Given this list of marker genes DAG1, CDON, WNT3, MUSK, CRPPA, KIAA0586, PIEZO2, PPP1R12A, CILK1, L1CAM (NCBI Gene Id 4268), STAG2, MBTPS2, POMGNT2, WDR11, PTDSS1, KIF7, LARGE1, NDUFB11, POU1F1 (POU class 1 homeobox 1), OTX2, EZH2, FGFR2, SOX2, PROP1, CSGALNACT1, LHX4, FOXA2, GPR161, CTBP1, RXYLT1, CSPP1, EHMT1, POMGNT1 (NCBI Gene Id 55624), COL18A1, GLI2, HCCS, ROBO1, PIGA, FKRP, KRAS, POMT2, NSD2, CDC42BPB, TBX4, FANCI, LETM1, DYNC1I2, ZSWIM6, CPLX1, PLCH1, FGFR1, PROKR2, FKTN, SOX3 (SRY-box transcription factor 3), ARNT2, POMK, B4GAT1, HESX1, FGFRL1, DHCR24, NFIX, COX7B, POMT1, CNOT1, COL4A1, B3GALNT2, RSPO2, SSR4, HYLS1, here is a description of the gene set: studied in species Homo sapiens Absent septum pellucidum Absence of the septum pellucidum (meaning translucent wall in Latin - SP), also known as the ventricle of Sylvius. The septum pellucidum is a thin, triangular double membrane separating the frontal horns of the right and left lateral ventricles of the brain. It extends between the anterior portion of the corpus callosum, and the body of the fornix and its width varies from 1.5 to 3.0 mm. Human Gene Set: HP_ABSENT_SEPTUM_PELLUCIDUM